Given this list of marker genes INTS7, ZNF143, POLR3B, EXOSC2, EXOSC8, EXOSC10, ELL, NHP2, ICE1, ELL2, EXOSC4, SNAPC1, EXOSC3, ZC3H8, ELL3, TUT1 (terminal uridylyl transferase 1, U6 snRNA-specific), TOE1, INTS9, SNAPC5, INTS13, INTS8, ZCCHC7, INTS6L, SNAPC3, INTS1, LARP7, SAGE1, METTL16, MYOD1, INTS11, INTS10, INTS12, CDK7, INTS5, INTS4, USPL1, ICE2, SAGE2P, METTL4, EXOSC7, MTREX, DKC1, RPAP2, INTS3, SNAPC2, FTO, NOP10, INTS6 (NCBI Gene Id 26512), EXOSC6, SNAPC4, USB1, CC2D1A, EXOSC5, MEPCE, EXOSC9, INTS14, INTS2, ZCCHC8, RBM7, here is a description of the gene set: The chemical reactions and pathways involving snRNA, small nuclear RNA, any of various low-molecular-mass RNA molecules found in the eukaryotic nucleus as components of the small nuclear ribonucleoprotein. Human Gene Set: GOBP_SNRNA_METABOLIC_PROCESS studied in species Homo sapiens